The following is a description of a gene set: Reactome Pathway: Events associated with phagocytolytic activity of PMN cells species: Homo sapiens part of: ROS and RNS production in phagocytes When neutrophils engulf bacteria they enclose them in small vacuoles (phagosomes) into which superoxide is released by activated NADPH oxidase (NOX2) on the internalized neutrophil membrane. The directional nature of NOX2 activity creates a charge imbalance that must be counteracted to prevent depolarization of the membrane and the shutdown of activity (Winterbourn CC et al. 2016). Also, protons are produced in the cytosol and consumed in the external compartment (for example, the phagosome) through the dismutation of superoxide. Both situations are largely overcome by a balancing flow of protons transported by voltage-gated proton channels, primarily VSOP/HV1, which are activated in parallel with the oxidase (Demaurex N & El Chemaly A 2010; El Chemaly A et al. 2010; Petheo GL et al. 2010; Kovacs I et al. 2014; Henderson LM et al. 1987, 1988). The pH of the phagosome is regulated by these activities. In contrast to the phagosomes of macrophages, in which pH drops following particle ingestion, neutrophil phagosomes remain alkaline during the period that the oxidase is active. Until recently, their pH has been accepted to lie between 7.5 and 8. However, in a 2015 study using a probe that is more sensitive at higher pH, an average pH closer to 9 was measured in individual phagosomes (Levine AP et al. 2015).<p>The superoxide dismutates to hydrogen peroxide, which is used by myeloperoxidase (MPO) to generate other oxidants, including the highly microbicidal species such as hypochlorous acid (Winterbourn CC et al. 2013, 2016)., and this is the list of marker genes: MPO, LPO